The following is a description of a gene set: studied in species Mus musculus Mouse Gene Set: GOBP_MITOCHONDRIAL_DNA_REPAIR The process of restoring mitochondrial DNA after damage., and this is the list of marker genes: Dna2, Primpol, Neurl4, Parp1, Trp53, Mgme1, Chchd4, Lig3 (NCBI Gene Id 28083)